Given this list of marker genes CLIC4, GATM, POGK, SNRK, GSTM2, PROX1, HOXA4, EPC1 (NCBI Gene Id 80314), MECP2, PRPF38A, PLCXD3, PAIP2B, TMSB15B, WDR82, FRAT2, NYAP2, WWC2, FBXW7, IKZF4, C5orf67, TRUB1, KIRREL3, GIGYF2, SESN1, SLC16A14, NUS1, EPB41L2, NLRP3, MAX, DAGLA, AKT3, C5orf24, GABBR2 (NCBI Gene Id 9568), CD80, NUSAP1, GRM5, HOMER1 (homer scaffold protein 1), CARMIL1, KHNYN, ASB6, RUFY2, DDIT4, ERBB3, CREB1, UNK, TNRC6B, CENPV, C6orf62, MAPK14, CCDC47, NAA20, UGCG, H3-3B, SYNE1, IL17RD, TET2, OGN, ZBTB39, ESR1, NPAS3, LRRC1, KCNAB1, SMAP1, EMX2, MAP2K4, MTHFR, TRIB2, C17orf58, RPS6KC1, CYTH3 (NCBI Gene Id 9265), INPP5B, PHF8, EMILIN3, LIN7C, ARRB1, TP53INP1, TACR3, PPP1R15B, CCN1, ANKRD13A, STAG2, BCL9, RGS2, MTHFD2 (methylenetetrahydrofolate dehydrogenase (NADP+ dependent) 2, methenyltetrahydrofolate cyclohydrolase), EP300, COA7, ZFYVE9, SLC6A17, RBM15, FUT9, SIRT1, CIITA, PDSS1, HERPUD2, RCOR1, NRAS, KLF6, TNKS2, PDS5A, CHD9, SPTY2D1, BTG1, CYRIB (NCBI Gene Id 51571), TMEM199, ELOVL6, CAV3, MSL2, YARS1, PPM1K, PRCP, LRP12, RSBN1, MTMR2, DEUP1, LAMC1, KCNK10, RFXANK, STK39, PRRC2C, ZDHHC16 (NCBI Gene Id 84287), STYX, CACUL1, RASSF10, KDM6B, LRRC73, MED28, CLIP2, ZCCHC14, MTF1, KIAA0040, NET1, MAT2A, BRWD3, H3-5, PDIK1L, SEPHS1, RAB5B, HIPK1, here is a description of the gene set: from publication Chen Y, Wang X (PMID 31504780) species: Homo sapiens Human Gene Set: MIR22_3P Genes predicted to be targets of miRBase v22 microRNA hsa-miR-22-3p in miRDB v6.0 with MirTarget v4 prediction scores > 80 (high confidence targets).